Given this list of marker genes APLP2, DUSP16, ATP5F1E, LAMB3, MPEG1, SNX4, KCTD20, BRD4, PJA1, ACTN1, MTDH, RERE, RPL36A, PTCD3, UBL3, ADSS2, USE1, IRAG2, DNASE1L1, PPP2CB, ALDH2, NDUFA6, SPECC1, PRDX4, ARL1, NFKBIZ, EMP1, MATR3, CHD7, IDH3G, ARIH2, DRG1, MRPL42, ATAD1 (ATPase family AAA domain containing 1), SRP9, STAM, HMGA2, SNX14, IL15, ANAPC5, RPS18, CARD19, IQGAP1, MYO5A, GABARAPL2, DOCK2, RPL6, EIF4EBP2, MKI67, TACC3, AP1AR, DENND4C, MECR, MBNL1, MYADM (NCBI Gene Id 91663), RPS26, SAP30, COPRS, PPP1R21, CTNNB1, RPL10, CYB5A, VPS41, CD83, LMO2, CAPN2, CPT1A, NAXE, LRBA, DDB1, CLEC4D, EIF3L, TPRG1L, GCH1, NAV2, H6PD, NONO, CLCN4, SMAP1, BCL10, LIMS4, HDAC2, SPTSSA, STMP1, COX17, TTC3, SRP14, ACYP2, OAT, CALCRL, RELL1, LSM14A, WDR6, CAPN7, MFF, KGD4, TMEM131, TMBIM1, HADH, MACIR, MRPS21, NEDD4L, LPL, GCSH, CAB39, TXNRD1, DAG1, WNK1, PRDX1, PTPRA, GNAI1, C4B, ACOT9, RASA3, VCL, UQCR11, GLUD1, PRPF38B, GSTO1, ALDH9A1, SLMAP (sarcolemma associated protein), TALDO1, CEBPD, BMP5, ZNF281, ADCY9, SPTAN1, RTN4, CMAS, APBB2, SQSTM1, ADD1, CD14, ACADM, CUEDC1, SERPINB6, FUT8, PLEC, RETREG1, ANKRD28, EIF1, CD47 (CD47 molecule), HNRNPH1, NPM1, COX6A1, NFKB1, EIF2D, ZSCAN21 (NCBI Gene Id 85010), ATP1B3, DNMT3A, NDFIP1, PON2, UNC119, CD9, TSG101, YWHAH, SLU7, SNRNP25, MYCBP2, DEGS1, TRA2B, CADM1, EMP3, DR1, ARL5A, PELI1, RPS5, MAP3K3, PTPN22, FNBP4, TTC17, ST3GAL5, RNF166, CRIP1 (NCBI Gene Id 1396), SLC27A1, PMP22, QDPR, AHNAK, ZCRB1, MFHAS1, ADSS1, BCL3, CUL3, GLCE, VBP1, PGRMC1, PRKCH, ANXA1, LXN, CKB, IGF1, SLC6A8, MRPS11, RGS10, CRYBG1, TRAF6, RPL36, FBXO45, RAB18, GNAQ, here is a description of the gene set: Studies of adult human hematopoiesis have until now relied on the expression of CD10 to define lymphoid commitment. We report a novel lymphoid-primed population in human bone marrow that is generated from hematopoietic stem cells (HSC) prior to the onset of CD10 expression and B cell commitment, and is identified by high levels of the homing molecule L-selectin (CD62L). CD10-CD62Lhi progenitors have full lymphoid (B/T/NK) potential, and show reduced myeloid and absent erythroid potential. Genome-wide gene expression analysis demonstrates that the CD10-CD62Lhi population represents an intermediate stage of differentiation between CD34+CD38- HSC and CD34+lin-CD10+ progenitors marked by down-regulation of TAL1 and MPL, upregulation of E2A, CD3E and IL2RG expression, and absent B cell commitment or RAG1/2 expression. Immature CD34+CD1a- thymocytes are also CD62Lhi and L-selectin ligands are expressed at the cortico-medullary junction, suggesting a possible role for L-selectin in human thymic homing. These studies identify the earliest stage of lymphoid priming in human bone marrow. studied in species Homo sapiens Genes up-regulated in the bone marrow CD34+ cells: CD38- versus MME- SELL+. Human Gene Set: GSE35685_CD34POS_CD38NEG_VS_CD34POS_CD10NEG_CD62LPOS_BONE_MARROW_UP from publication Kohn LA, Hao QL, Sasidharan R, Parekh C, Ge S, Zhu Y, Mikkola HK, Crooks GM (PMID 22941246)